The following is a description of a gene set: species: Homo sapiens from publication Jeffrey KL, Brummer T, Rolph MS, Liu SM, Callejas NA, Grumont RJ, Gillieron C, Mackay F, Grey S, Camps M, Rommel C, Gerondakis SD, Mackay CR (PMID 16474395) In the present study we used Affymetrix oligonucleotide microarrays to produce gene transcription profiles for the major leukocyte types in humans. This comprehensive dataset enabled us to not only establish which genes were expressed in each leukocyte type, but also which genes were expressed in each subset after activation. The used of a comprehensive dataset of gene profiles from all the major human leukocyte subsets enabled a novel and powerful means for identification of genes associated with single leukocyte subsets, or different immune paradigms. Genes up-regulated in comparison of macrophages versus B cells. Human Gene Set: GSE3982_MAC_VS_BCELL_UP, and this is the list of marker genes: RHEB, GPD1, NEIL3, CYP1A1, TNFSF8, CDKN1A, TPSB2, NFE2, GALNS, TCIRG1, CLEC4M, CXCL10, PSEN1, LAPTM4A, ASPHD1, TALDO1, SCG5, GK, ACP2, DIXDC1 (DIX domain containing 1), CIT, CSPG4, TMEM51, CTNNA1, COX7A2, IPCEF1, SCCPDH, FZD5, SASH1, WWTR1, MYO6, PSMD11, KCNS3, MT3, GCNT2, RNASE2, NUMB, DPYSL2, NCOA4, VANGL1, FCN1, HS3ST2, PAPSS1, RAB8B, EPHX1, DUSP7, CDA (NCBI Gene Id 978), CHN2, MPP1, TACSTD2, KLHL28, PIMREG (NCBI Gene Id 79996), LPP, FOSL1, AFF4, ERO1A, OR7E36P, PHACTR2, MTMR11, BMP1, MICAL2, APOBR, PLA2G15, KPNA2, NR4A3, BEX4, RASSF4, CTNS, PLEK2, DST, PROCR, CBR3, PDXK, SYTL2, TNPO3, ACOT7, TMEM184C, RAB11A, PBX3, ATP9A, GRK3, C1orf216 (chromosome 1 open reading frame 216), LUZP4, TREM1, DLC1, GSC2, CHST8, DYNC1I2, TGOLN2, AK4, GPD2 (NCBI Gene Id 2820), PDE4A, RBPJ, MYD88, BCL6, HSPA1A (heat shock protein family A (Hsp70) member 1A), SAP30, DENND1A, RCAN1, INHBA, ZMAT4, OAS3, DEFB126, HP, CD83, CHP2, PRKCH, RAC1, TLN2 (NCBI Gene Id 83660), MFGE8, ERC2, SLC22A4 (solute carrier family 22 member 4), PAQR4 (NCBI Gene Id 124222), SKAP2, KCNMB1, SEC14L2, TAOK3, ADGRA3, DHRS11, SLC12A7, GABRA3, FHL1, DIRAS2, CMAS, TMEM70, ARSB, TCP11L1, FKBP5, MTCH2, ADH5, PPP2R3A, AHCYL1, PIK3CB, QPRT, CYFIP1, TMEM53, PCDHB11, PON3, TOP2A, MMP3, DBI, CD86, VSIG10, SLC11A1, RASAL2, TNFRSF9, FAM76A, NLRP3, ZMIZ1 (zinc finger MIZ-type containing 1), FOXO3, FLT1 (fms related receptor tyrosine kinase 1), EXOC6B, CREM, SPSB1, P4HA2, GABARAPL1, SERINC3, SCARF1, SQOR, LUZP1, FUCA1, LRRC8D, IDH1, CYP27B1, MLF1 (NCBI Gene Id 4291), DENND1B, EML4, PLPPR2, NDUFB6, GABBR2, ANXA9, ELOC, RBP4, PTPN13, OCRL, CDCA8 (NCBI Gene Id 55143), UBL4A, GAPDHS, PLXNA1, GNPDA1, RAB5IF, CREBL2 (NCBI Gene Id 1389), ITPRID2, DDO, MYO10, TIMM8A, SPIN1, COX6C, GFPT1, ABCC3, HNRNPH2, S100A8, LAMA4, PLAU, STX3, DYNC1LI2, DOCK3, TLR4, DTX2, ACO1